Given this list of marker genes CLTCL1, NTRK1, ELP1, RETREG1, LIFR, KIF1A, WNK1, SCN9A (sodium voltage-gated channel alpha subunit 9), ZFHX2, ALG11, here is a description of the gene set: Human Gene Set: HP_DECREASED_CORNEAL_REFLEX An abnormally reduced response to stimulation of the cornea (by touch, foreign body, blowing air). The corneal reflex (also known as the blink reflex, normally results in an involuntary blinking of the eyelids. Decreased corneal reflex studied in species Homo sapiens